Given this list of marker genes ST13, CDK18, CLEC2B, SLC12A4, P4HA1, TUBA1A, PITX2, GRSF1, ADAR, DHPS, PRKAR1A (protein kinase cAMP-dependent type I regulatory subunit alpha), FDFT1, NEAT1, TRPC1, NDUFS4, here is a description of the gene set: Ageing results in a progressive, intrinsic and generalised imbalance of the control of regulatory systems. A key manifestation of this complex biological process includes the attenuation of the universal stress response. Here we provide the first global assessment of the ageing process as it affects the heat shock response, utilising human peripheral lymphocytes and cDNA microarray analysis. The genomic approach employed in our preliminary study was supplemented with a proteomic approach. In addition, the current study correlates the in vivo total antioxidant status with the age-related differential gene expression as well as the translational kinetics of heat shock proteins (hsps). Most of the genes encoding stress response proteins on the 4224 element microarray used in this study were significantly elevated after heat shock treatment of lymphocytes obtained from both young and old individuals albeit to a greater extent in the young. Cell signaling and signal transduction genes as well as some oxidoreductases showed varied response. Results from translational kinetics of induction of major hsps, from 0 to 24 h recovery period were broadly consistent with the differential expression of HSC 70 and HSP genes. Total antioxidant levels in plasma from old individuals were found to be significantly lower by comparison with young, in agreement with the widely acknowledged role of oxidant homeostasis in the ageing process. Human Gene Set: VISALA_RESPONSE_TO_HEAT_SHOCK_AND_AGING_UP studied in species Homo sapiens Genes up-regulated after heat shock in peripheral lympocytes from old donors, compared to those from the young ones. from publication Visala Rao D, Boyle GM, Parsons PG, Watson K, Jones GL (PMID 12618007)